The following is a description of a gene set: studied in species Mus musculus Genes predicted to be targets of miRBase v22 microRNA mmu_miR_7002_3p in miRDB v6.0 with MirTarget v4 prediction scores > 80 (high confidence targets). from publication Chen Y, Wang X (PMID 31504780) Mouse Gene Set: MIR_7002_3P, and this is the list of marker genes: Cpne8, Cilk1, Amotl1, Ccdc6, Daam1, Gria2, Rab33b, Anks1b, Fam20b, Sgpl1, Bicd1, Sh3rf1, Pkp4, Fgf12, Ptpra, Socs3, Zfp609, Tspan5, Ebf2, 2510009E07Rik, Trim9, Agap1, Arhgap15, Exo1, Ark2c, Tyw3, Adipor2 (adiponectin receptor 2), Ikzf1, Glce, Tmed8, Aif1l, Mast4, Fbxo41, Thoc2, Tmem151a, Lasp1, Zfp654, Tmem132b, Kif21b, Extl3, Cdc42se2, Plppr4, Brcc3, Gpr45, Rab6a, Cdh8, Galnt13, Slc6a1, Flrt3, Zfp236, Kalrn, Mdfic, Mindy2, Zbtb11, Mospd1, Mdga2, Nepn, Rnf114, Robo2, Msi2, Acsl1, Larp4b, Anxa13, Plcxd2, Nyap2, Ptp4a1, Clec2e, Cd209a, Plpp3, Abcg4, Gfpt1, Trarg1, Gnas, Otud7b, Grip1, Tmx1, Shoc2, Cacna1g, Itm2c, Rassf2, Kirrel3, Arf6, Scgb1b24, Kcnb1, Kdm5a, Cntn1, Pheta1, Klf12, Pi4k2a, Sertad4, Hcn3, Serinc5, Usp32, Ripor2, Robo1, Nup50, Sgcz, Pcnp, Stam2, Adgrb3, Herpud2, B3gat1, Fam241b, Cttnbp2nl, Golga7, Rnf41, Gnb1, Grik2, Snx4, Pik3c2a, Ugt8a, Lmo7, Klhl13, Ddx41, Runx3, Sntb2, Scn2b, Shc4, Dlg2, Plxnc1, Slc5a3, Cacybp, Zfp202, Prkg1, Kcnip3, Ppargc1a, Hp1bp3, Scai, Bcl9, Insyn2a, Rorb, Pex5l, Abhd14a, Pou2f1 (NCBI Gene Id 18986), Pde12, Fgd4, Mbnl2, Col19a1, Nectin1, Ube3a, Hs3st2, Pold3, Slco5a1, Ago2, Nacc1, Bpnt2, Grm1 (NCBI Gene Id 74875), Ranbp10, Hcfc1, Msl2, Exd2, Ube2h, Onecut2, Mier3, Nsd3, Cbx5, Pcdh8, Eif5a2, Nrxn3 (neurexin III), Lrat, Sh3kbp1, Wdr44, Lgr4, Ret, Mpzl2, Jade3, Ddx5, Dbn1, Cped1, Tent5d, Jade1, Lypd6b, Diras1, Mid2, Rcbtb1 (NCBI Gene Id 71330), Dennd10, Epha5, Pbx2, Mfhas1, Micall1, Sephs1, Slc66a3, Hoxd10, Hectd2, Sorbs1, Shisa6, Rgs17, Nhsl3, Lcorl, Serpini1, Gskip, Kcnh1, Pdgfra, Hivep1, Cd200r1, Faap100, Dcbld2, Plekhg1, Ccer2, Tub, Chm, Magi2, Reln, Sv2a, Vat1, Yeats4, Bend3, Plekhf2, Slc16a7, B3gat2, Tmem25, Nmt2, Nrcam (NCBI Gene Id 77467), Sh2d1a, Rabep1, Nr1d2, Gramd4, Dcun1d1, Rnf103, Rhoq, Cacna1i, Ctnnd2, Zmiz1, Rhobtb1, Dazap1, Sec61a1, Insyn2b, Bltp3b, Pdzd4, Tmem178, Mdga1, Nlrp6, Plgrkt, Ccdc88a, Creb1, Gpr161, Smchd1, Kcnk1, Hlf, Rnf38, Jade2, Tbc1d8b, Pclo, Cul3, Bmi1, B3galt2, Snx18, Runx2, Cep55, Hecw1, Inhbb, Napepld, Phc3, Rara, Slc1a2, Mbnl1, Tanc2, Parp12, Arpp19, Zeb2, Wnt2b, Myorg, Fbxl14, Npas2, Gabrb3 (GABRB3, gamma-aminobutyric acid type A receptor subunit beta 3), Vopp1, Eif2ak3, Retnlg, Ankrd27, Rabgap1l, Ssr3, Purb, Cert1, Asic1 (NCBI Gene Id 11419), Rfx3, Hapln1, Med17, Rimbp2, Rnf139, Ermp1 (NCBI Gene Id 52008), Ptprr, Cntnap2, Mitf, Trpc3, Fn1, Sema6a, Camkk2, Ano4, Fzd4, Sorcs1, Ncan, Ppp4r3b, Sertad2, Pum2, Gucy1a2, Pcgf2, Bcl11b, Trhde, Gnai2, Elfn2, Mtmr1, L3mbtl3, Setbp1 (SET binding protein 1), Nav3, Ell2, Pld5, Gdpd5, Kcnd2, Klf9, Atosa, Zfx, Adgrl1, Ebf3, Naa15, Shank2, Kcnj16, Ints14, Fam3c, St18, Sfxn5, Ms4a6d, Mvb12b, Rab3b, Syt13, Gpr153, Ubqln2 (ubiquilin 2), Kctd9, Igsf11, Brinp3, Man2a1 (NCBI Gene Id 17158), Calcrl, Klhl29, Specc1l, Chst8, Ubr3, Ppp4r2, Satb2, Nsa2, Dnal1, St8sia4, Piezo2, Ppp2r5a, Thsd7a